Given this list of marker genes Tbx21, Cd69, Loxl3, Tnfsf18, Lgals1, here is a description of the gene set: Any process that stops, prevents or reduces the frequency, rate or extent of T-helper 17 cell lineage commitment. studied in species Mus musculus Mouse Gene Set: GOBP_NEGATIVE_REGULATION_OF_T_HELPER_17_CELL_LINEAGE_COMMITMENT